Given this list of marker genes ABHD17A, TTBK2, MAP1A, ABHD17C, ABHD17B, here is a description of the gene set: studied in species Homo sapiens Any process that stops, prevents or reduces the frequency, rate or extent of protein localization to microtubule. Human Gene Set: GOBP_NEGATIVE_REGULATION_OF_PROTEIN_LOCALIZATION_TO_MICROTUBULE